Given this list of marker genes CYP11B2, HSD3B1, POMC, HSD11B1, CYP17A1, SERPINA6, CYP21A2, CYP11B1, HSD11B2, HSD3B2 (hydroxy-delta-5-steroid dehydrogenase, 3 beta- and steroid delta-isomerase 2), here is a description of the gene set: Glucocorticoid biosynthesis Human Gene Set: REACTOME_GLUCOCORTICOID_BIOSYNTHESIS species: Homo sapiens